Given this list of marker genes VRK1, NFE2, PADI4, RAB27A, TIMELESS, TOPBP1, GCHFR, MTMR11, CENPH, HP, SAC3D1, CCNB1, MXD3, PXMP2, KIF20B, MCM8, RMI2, EZH2, CIT, ATAD2, TOP2A, SAPCD2, PCNA, KIF18B, H1-5, GRK6, RECQL4, CDK1, CCNF, CDCA3, FBXO5, NCAPD2, CENPA, HMMR, PRIM1, NDC80, FOXM1, RNASEH2A, GOLM1, KCNE5, TNNT1, ODF2, TFDP1, DBF4, SMC2, TCF19, BTG3, CDCA7, C12orf75, PTTG1, ARHGAP11A, RANGAP1, MAD2L1, CIP2A, BUB1B, TMX4, MS4A3, AURKB, FAM72A, ARMH1, KNSTRN, BIRC5, DNAJC9, MND1, ASF1B, NLRC5, RFC4, PCLAF, NRGN, AZU1, ACOT7, C19orf48P, ERLIN1, H2AC13, SKA3, CDT1, GTSE1, UBE2T (ubiquitin conjugating enzyme E2 T), HMGB3, DHFR, CEP55, MELK, AURKA, NCAPH, NSD2, CHEK1, GMNN, POC1A, SPC24, BUB1 (NCBI Gene Id 699), SGO2, ACAP3, RNASE2, SMC4, UBE2S (NCBI Gene Id 27338), MCM6, SKA2, IGF2BP2, KIF11, FASN, H2AC17, RFC3, RFLNB, CDK5RAP2, KNTC1, PKMYT1 (NCBI Gene Id 9088), H3C2, KIF23, RRM1, UPK3A, NKG7, CLEC11A, SPDL1, KIF20A, E2F2, PRC1, ASGR2, LMNB1, CKS1B, NUCB2, ORC1, KBTBD11, CENPE, H3C8, PHGDH, ATAD5, HELLS, CD2, RACGAP1, MCM4, NT5DC2, SGO1, SPAG5 (sperm associated antigen 5), H2AC14, FLNB, ANLN (NCBI Gene Id 54443), CDC45 (cell division cycle 45), RMI1, TUBA4A, MCEMP1, CDC20, S100P, IGFBP7, KIF2C, H2AC12, ORC6, GINS2, TMEM170B, TMED8, H3C10, MYBL2, TESMIN, NUSAP1, C21orf58, GINS4, CDC25B, CENPM, KIF14, SLC44A1, PSRC1, DDB2, PHF19, CDA, H2AC16, H2AC11, DSN1, RPL39L, ASPM, UBE2C, LIG1, NCAPH2, HERC5 (HECT and RLD domain containing E3 ubiquitin protein ligase 5), MPO, LRG1, TK1, FAM111A, RFWD3, DIAPH3, FAM107B, DYNC2I2, ASRGL1, CENPF, DEPDC1B, OAF, CES1, NRM, CCDC34, NDC1, LMNB2 (NCBI Gene Id 84823), KIF15, RFC5, CLSPN, PDSS1, KIFC1, GGH, BST1, ANAPC15, MPHOSPH9, UHRF1, SHCBP1, CKAP4, DDX11, NCAPG2, TPX2, FANCA, CEP152 (NCBI Gene Id 23701), PLK1, TMPO-AS1, H2BC9, HIRIP3, NCAPD3, TMEM106C, HJURP, CCNB2, CHAF1A, NCAPG, BRCA2, CBX5, SAP30, CDKN3, CITED4, PRR11, TROAP (trophinin associated protein), PDXK, KIF22, PAQR4, MCM2, BCL2L12, FAM72B, SQLE, RNF26, SNRNP25, BARD1, ZWINT, HEBP2, CCNA2, APOBEC3B, MTFR2, RRM2, GPSM2, MGST1, S100A12, MCM3, MDC1, SLC2A4RG, RAD51AP1, CHTF18, RAB3D, MCM7, H2AX, CDCA5, ARHGEF39, IGF2BP1 (NCBI Gene Id 201194), FANCD2, SPC25 (NCBI Gene Id 57405), BRCA1, TYMS, CCDC18, SAE1, RAPGEF2, CKAP2L, CENPN, CENPW, KNL1, MKI67, MIS18A, PTK2B, CEP78, CKAP2, NUP210, ALYREF, CDCA8, CARHSP1, LRR1, DLGAP5, DTYMK, IGFBP2, INCENP, CDCA4, FANCI, CENPK, H3C3, TEDC1, SERPINB8, RNASE3, CENPU, CKAP5, FEN1, MT1X, NUF2, here is a description of the gene set: Human Gene Set: HE_LIM_SUN_FETAL_LUNG_C2_PROMONOCYTE_LIKE_CELL species: Homo sapiens from publication He P, Lim K, Sun D, Pett JP, Jeng Q, Polanski K, Dong Z, Bolt L, Richardson L, Mamanova L, Dabrowska M, Wilbrey-Clark A, Madissoon E, Tuong ZK, Dann E, Suo C, Goh I, Yoshida M, Nikolić MZ, Janes SM, He X, Barker RA, Teichmann SA, Marioni JC, Meyer KB, Rawlins EL (PMID 36493756) Promonocyte-like